Given this list of marker genes Clps, Pnliprp1, Guca2b, Alpi, Pir, Pnlip, Amy2a2, Sis, Amy2a4, Lipf, Chit1, Pnliprp2, Gucy2c, Amy2a5, Mgam, Cel, Amy2a3, Chia1, Lct, Guca2a, here is a description of the gene set: Mouse Gene Set: REACTOME_DIGESTION Digestion studied in species Mus musculus